Given this list of marker genes WNT10A, ARID1B, FOCAD, KRT74, SMARCA2, SVBP, PADI3, ASL, GNPTAB (NCBI Gene Id 79158), ERCC6, OFD1, GJA1, NECTIN1, PPP1R13L, LPAR6, KRT17, RPL21, ERCC8, PQBP1, BCS1L, here is a description of the gene set: studied in species Homo sapiens Hair that lacks the luster (shine or gleam) of normal hair. Human Gene Set: HP_DRY_HAIR Dry hair